Given this list of marker genes SHROOM4, CAP1, SPTB, FLOT2, MYRIP, SPTBN5, FLOT1 (flotillin 1), GMFB, MYZAP, PPP1R9A, WASL, COTL1, SPTA1, CDH1, PRKCB, EPB41L2, AKAP13, ACTN1, HIP1, MYADM, PLEKHH2, LLGL2, RTKN, HIP1R, CIB2, PLS1, ACTN3 (NCBI Gene Id 89), ACTN2, LLGL1, MYO1A, WDR1, SHROOM3, CLDN5, ACTN4, GMFG, VCL, IQGAP1, EEF1A1, CAPN2, PJVK, SPTBN2, LANCL2, RDX, MAEA, ANLN, TRPV4, NF2, CFL1, SPTAN1, SPTBN4, PIEZO2, PIEZO1, MYH9, MED28, FCHSD1 (FCH and double SH3 domains 1), SLC2A1, TMC2, KNCN, MTSS2, GSN, PPP1R9B, GYS2, CALD1, CALB1, DLC1, DSTN, KRT19, COBL, CALB2, MISP, SHROOM1, SPTBN1, CORO1A, SHROOM2, SNX9, LASP1, CDH2, MLPH, ACTR2, RAPGEF3, here is a description of the gene set: Human Gene Set: GOCC_CORTICAL_ACTIN_CYTOSKELETON species: Homo sapiens The portion of the actin cytoskeleton, comprising filamentous actin and associated proteins, that lies just beneath the plasma membrane.